Given this list of marker genes PLPP1, BID, PHLPP1, NR4A2, MGARP, DUSP5 (NCBI Gene Id 1847), CETN1, SOCS2, MAPRE2, RBIS, REEP3, IL18R1, MTMR3, TTN, BCL2L15, GABARAPL1, PTPRS, RGS1, PRR13, FCGR2B, TSPAN13, ARHGAP20, HUWE1, DENND4A, PLCB3, ICOS, PTPN13, IL2RA, GPR15, DUSP1, PENK, NTN4, PAQR3, SYNGR2, ALDOC, RNASE4, FAM162A, TNFRSF1B, IRAK1BP1, ITGB8, TNFSF11, NRN1 (neuritin 1), MGAT5, DTWD1, OAS1, FBXO17, ATG9B, FOXP3, TASP1, S100A4, GCH1, SDHAF1, NOTCH2, ENO3, ARRDC4, MBNL3, CHCHD10, CAVIN1, RAB8B, PEX11A, DNAJB13, MIF4GD (NCBI Gene Id 57409), APOC4, CASP1, GCNT1, ITGB1, SOBP, PLAGL1, S100A10, IKZF4, ITGAE, AHR, TSPAN3, HEMK1, PRDM1, EBI3 (Epstein-Barr virus induced 3), NXPE4, SEPTIN8, NIBAN1, CCR6, CRIM1, CD44 (CD44 molecule (IN blood group)), PTPN9, LIMA1, PDCD1, HBEGF, SH3BGRL2, LAMB2, RNF135, DUSP4, MYADM, GKAP1, PNP, TNFSF8, FAM241B, IFT74, TMEM126A, THOC7, NAF1, NFIL3, TMEM140, PEAK1, NEFH, METTL6, ATXN1, RSPH3, CCDC136, VAV2, KIF5C, MAF, CD83, CD38, TGIF1, CHST11, PIM1, PMEPA1 (NCBI Gene Id 56937), GZMB, GEM, TNFRSF4, IFNGR1, FAM210B, PHETA2, FOSL2, ATOSB (NCBI Gene Id 80256), WLS, LCLAT1, PRNP, BCL2L1, ACOT7, ARL5A, CXCR6, PSEN2, PLSCR1, PPP2R3A, GBP4, AHCYL2, PPIE, IL1R1, PCTP, SPNS3, IL1RL1, THBS3, MYH8, NR0B1, TTC39C, LGALS3, PROS1, CREB3L2, CCR2, CXCR3 (C-X-C motif chemokine receptor 3), CAPSL (NCBI Gene Id 133690), GSTO1, SRGN, IKZF2, S100A6, GADD45G, PTGER4, SLC15A3, PLAAT3, PRKRA, RNPEP, CSRP2, NRP1, RAPSN, MKX (NCBI Gene Id 283078), PVT1, PRKAG2, NKG7, DGAT2, PLA2G4F, PDZK1IP1, MDFIC, IL1R2, BHLHE40, GADD45B, CISH, EOMES, IGF1R, HLA-B, EID2, SLC22A2, PTGER2, KLRG1 (killer cell lectin like receptor G1), PRRC2A, FGL2, TTC28, MED7, BCL2A1, CCL5, CTLA4, ODC1, PLCB4, CASP4, KLF9, OSBPL3, TMEM176B, MCUB, TTC39B, TPI1, IGSF3, here is a description of the gene set: Genes up-regulated in comparison of thymus regulatory T cells versus thymus conventional T cells. from publication Feuerer M, Herrero L, Cipolletta D, Naaz A, Wong J, Nayer A, Lee J, Goldfine AB, Benoist C, Shoelson S, Mathis D (PMID 19633656) studied in species Homo sapiens Human Gene Set: GSE7852_TREG_VS_TCONV_THYMUS_UP Comparisons of global gene-expression profiles revealed a greater distinction between CD4+ Treg cells and CD4+ conventional (Tconv) T cells residing in abdominal (epidydimal) fat versus in more standard locations such as the spleen, thymus and LN.